Given this list of marker genes WWOX, PPFIBP1, KCTD7, TBC1D24, ATP6V0C, IER3IP1, PLCB1, AHDC1, GRIN2A, SCN1A, EHMT1, KCNH5, SCN8A, CNTNAP2, NHLRC1, CEP85L, TRIM8, SCN2A, SZT2, KCNB1, PSAP, KDM6A, PPP2CA, FIG4, EPM2A (NCBI Gene Id 7957), KCNQ3, GABRG2, PIGA (NCBI Gene Id 5277), ATP1A2, MAST3, KCNT1, ADAM22, DEPDC5, PRRT2, LGI1, POLG, PDSS2, PACS2, SLC38A3, SLC22A5, SLC25A22, KCNMA1, SLC12A5, TBCK, MICAL1, KMT2D, RELN, MTFMT, SRPX2, PUS3, STXBP1, GAL, KCNJ11, KCNQ2, here is a description of the gene set: Human Gene Set: HP_BILATERAL_TONIC_CLONIC_SEIZURE_WITH_FOCAL_ONSET A bilateral tonic-clonic seizure with focal onset is a focal-onset seizure which progresses into a bilateral tonic-clonic phase. species: Homo sapiens Bilateral tonic-clonic seizure with focal onset